The following is a description of a gene set: Th1 and Th2 cells arise from a common precursor cell in response to triggering through the TCR and cytokine receptors for IL-12 or IL-4. This leads to activation of complex signaling pathways, which are not known in detail. Disturbances in the balance between type 1 and type 2 responses can lead to certain immune-mediated diseases. Thus, it is important to understand how Th1 and Th2 cells are generated. To clarify the mechanisms as to how IL-12 and IL-4 induce Th1 and Th2 differentiation and how TGF-beta can inhibit this process, we have used oligonucleotide arrays to examine the early polarization of Th1 and Th2 cells in the presence and absence of TGF-beta after 0, 2, 6 and 48 hours of polarization. from publication Lund R, Aittokallio T, Nevalainen O, Lahesmaa R (PMID 14607935) studied in species Homo sapiens Genes down-regulated in CD4 T cells activated by anti-CD3 and anti-CD28: TGFB1 and IL4 (48h) versus IL-12 (48h). Human Gene Set: GSE2770_TGFB_AND_IL4_VS_IL12_TREATED_ACT_CD4_TCELL_48H_DN, and this is the list of marker genes: DNAJA2, TUBA1B, YY1AP1, CPQ, DDX6, ACTG1, CAMK1D, ALG8, NCKAP1L, TUBB, KIF18A, TP53INP2, NSMAF, PARVB, CDK5R1, NCK2, CDK12, TOR1A, SOCS1, TRBV24-1, IKBKE, ARID3B, BIRC5 (baculoviral IAP repeat containing 5), PHLDA1, U2AF2, UBC, IGHD, LYSMD2, GPR137B, ACAA2, IL10RA, DDX39A, PJA1, WDR74, TXNDC17, FOXP1, AGO2, FRAT2, RSBN1L, SLC12A7, ARHGAP17, TENT4A, EIF3A, HECTD1, SOD2, PPIF, CTPS1, MEX3C, ARMCX3, SCAMP1, TEX10, DCTN6, USP24 (NCBI Gene Id 388634), RABL3, PIK3R5, DNAJB9, BTG2, SUN2, FNDC3A, RNF7, RMND5A (required for meiotic nuclear division 5 homolog A), IL12RB2, VPS51, SMIM3, DNAJB11, NDUFB8, JMJD6, RBM39, ADM (NCBI Gene Id 133), ZNF827, BAG3, NUP50, BACH2, ZNF512B, RAB21, MCM7, SMAD7, ZFP36, RPTOR, AKAP1, PSMG4, MIDN, AMD1, HSPA14, SIK2, POLR1D, EIF4E3, RCBTB2, TNFRSF1A, RABGAP1L, RHOG, LPP, MCMBP, PLOD3, ADAR, GPR65, GNB5, CREM, ZNF792 (NCBI Gene Id 126375), DPYSL2, PITPNC1, LGALS8, TICAM1, LRCH1, MRPL54, DNAJC9, TRABD, ID3, SRSF3, CBR3, CALHM2, CD70, ABHD17B, PTRHD1 (NCBI Gene Id 391356), PRSS23, CCL4, DPF2, ATP10A (ATPase phospholipid transporting 10A (putative)), IKZF2, MSI2, KDM6A, ADCY3, TRIB1, DCAF4 (DDB1 and CUL4 associated factor 4), FCER1A, C12orf75, PPBP, EPHX2, APOBEC3C, IL18R1, AKAP8, CCNH, DNMT3A, SLCO3A1, DDB2, ECI1, TNFAIP8L2, UBP1, TASOR2, GBE1, CLIP1, MAN2A1, EIF2AK2, CPPED1, SINHCAF, MRPL23, SGK1, NAP1L4, SYNM, MLLT11, IRGQ (NCBI Gene Id 126298), FOSL2, RAP1B, CXCR6, SV2A, KCNAB2, SIK1, FURIN, TENT5A, ELL, ATP8B2, NDEL1, SIGIRR, PLEKHO2, HSPE1, BEX4, FCRL2, LTA, DYNLL2, CDC25B, PICALM, ENSG00000291211, CKAP4, SKAP1, POLE4, OTUB1, ALYREF, SLC7A1, ARHGAP1, AIP, MICALL1, ADGRE1, FAM110A, RNF19B, ITM2B, BAK1, PATL2, SMYD2, CCR9, LANCL2, UTP18, DLL1, MIATNB, PTMA, SFN, QSER1, DCTN5, ITCH, MTHFD2